Given this list of marker genes SLC30A5, TSC22D2, ZNF24, WDR48, SECISBP2L, PPP6C, DHX36, CBX8, STAG1, CBX3 (NCBI Gene Id 82756), RPS6KA3, CLDN3, PPP2R2A, WNT10A, PPARGC1A, EIF5A, KYAT1, KDM2A, EGR4, PTMA, ZNF367, FGF14, GOLGA5, ZFY, NTMT1, RABL6, DACT1, TAOK2, TLE3, LTBP1, GPR3, KCNA2, SSTR2, S1PR2, ASPHD1, ATP2A2, SHC3, NINJ1, PSMD12, NDUFB2, AZIN1, SRPRA, MAP1A, RUNDC3A, SRSF1, PDZD8, FAU, MIR137HG, CCNI, PTOV1, DNM3, CHPF, GPBP1, FAM76B, HOXC11, PPP1R15A, ATP10D, BRAF, DUSP1, ZNF462, CCDC148, NR4A1, ZNF687, IRX6, ELMOD1, SLC31A1, GRM3, TP53INP2, ARF4, FOXA1, C1orf21, CDK2AP2, GLOD4, PPP2R2B, IRF2BPL, KAT8, GTF2A1 (NCBI Gene Id 50857), GSTCD, PRR3, NEK1, INTS12, DMTN, C1QTNF7, MCAM, LENG9, SLC20A2, NR4A2, HOXC10, LMTK2, PTGES3, SEC63, LGR5, TBRG4, CLDN7, MRC2, ADAMTS3, MORF4L2, SCG2, ADIG, RPRD1A, EHD4, TMEM263, SATB2, HMGB1, TSPYL5, SGIP1, STT3A, FOSB, ZBTB21, SLC18A2, RBMS2, DPH3, GNL1, SHISA6, MARCHF6 (NCBI Gene Id 10299), PDE7A, DNAJC27, OSBP, CRY2, STX5, COQ10A, SLC39A13, SRGN, ANK2, NOL4, FSTL5, ZEB2, SMARCA1, KCNA6, IKBKB, PSME3, CD160, SH2D2A, GOLGA2, ALDOC, PKP4, RPL41, PAFAH1B1, EIF4A1, CCER1, ZC3H10, TRIB1, CALCRL, ZBTB4, ZNF711, MAP3K13, NR3C1, RAB1A, FLRT3, OXNAD1, EGR3, TBX20, CEP83, ATP6V0C, HABP4, CFAP68, CHGB, GNAS, NUMBL, ATAD5, MIR9-1HG, HIC2, FKBP7, RFX1, SIK1 (salt inducible kinase 1), CALD1, ETF1, UFC1, TBC1D23, PHF20, ERC1, GJD2, CCDC24, NEDD9, MAP1LC3A, BCL2L13, U2AF1L4, SCAMP5, CALM2, LMBRD1 (LMBR1 domain containing 1), FOXD3, PITX2 (NCBI Gene Id 5308), C6orf62, PDLIM3, TRMT61B, HDAC6, ITFG2, RHOBTB1, GEM, ANKS1B, TCEAL9, NAP1L2, EIF1, PRKAG1, PDP1, KIRREL3, NR4A3, DDX51, SMARCE1, SACM1L, FAM117B, LETM2, FXR2, FAM50A, RANBP2, ZNF516-DT, MASTL, PTGR3, RAB6A, RBBP8, TOR1AIP1, OSR1, AGPAT1, PURB, HOXB3, HNRNPA2B1, SRCIN1, CCN1, ABCF3, SLC25A25, TMEM175, MAF (MAF bZIP transcription factor), KDELR3, MED15, ERF, RUSC1, PNMA3, SYNGR3, YWHAG, UBQLN2, ADNP, SARAF, MAFF, RAB2A, RNF5, PTP4A1, FGF9 (fibroblast growth factor 9), ELOVL5, CELF6 (NCBI Gene Id 60677), FOXRED1, ATF1, H4C8, ARMCX6, C11orf87, PLK4, EPB41, PSENEN, SOX9, CSTF3, CD2AP, CKB, TSPAN13, FZD7, DDX3X, UBAP1, ZNF184, TSC22D3, SLC25A37, GNG4, CXCL16, HS6ST2, ARG2, USP48, MRPL49, TAF10, NKX2-2, RFX5, NEUROD6, TNFAIP8, PELI3, MRM3, EPC1, CBY2, RUSC1-AS1, PNMA6A, CREB1, YJU2B (NCBI Gene Id 81576), PTCH1, GRK6, POLR2A, GRIN2B, ZMYND15, ID1, EGR2, GAK, HDX, SLC36A3, AKIRIN1 (akirin 1), TRPC1, SMIM19, NR6A1, ARL4D, here is a description of the gene set: Genes having at least one occurrence of the motif SYTACGTCAC in the regions spanning 4 kb centered on their transcription starting sites. This matches the E4F1 transcription factor binding site V$E4F1_Q6 (v7.4 TRANSFAC). Human Gene Set: E4F1_Q6 species: Homo sapiens